Given this list of marker genes YRDC, IL12A, IFT140, RNASEH2A, DNASE1L3, PROKR2, TRAF7, MT-TC (mitochondrially encoded tRNA-Cys (UGU/C), NCBI Gene Id 4511), RPS20, ARX, PRF1, GUCY2D, RD3, STAT4, AFG2B (AFG2 AAA ATPase homolog B), RRM2B, LRAT, CPT1A, LUZP1, PRNP, UBE4B, SP110, PAH, ADAR, MSH2, AGR2, PNPLA6, MMP23B, CBS, PRKCZ, HLA-DPA1, EPCAM, MEFV (MEFV innate immunity regulator, pyrin), PRTN3, GDF6, C4A (complement C4A (Chido/Rodgers blood group)), ATP1A3, SLC1A3, DCC, TTR, TPRKB, POMT1, CRX, CTLA4, MT-CO1, SPATA7, WDR73, USP45, TBC1D24, CRB1, PCYT1A, PMS2, HESX1, MT-TS2, TGFBR3, CFHR3, CYP26C1, MT-CO3, ADSL, LSM11, MT-TL1, TUBB2B, TUBB4B, CRELD1, PRRT2, COQ2, AKT3, PRDM16, PEX7, ARNT2, SNORD118, MT-TQ, OSGEP, MT-ATP8, BAP1, BMPR1A, SMARCAL1, FKTN, SCN1A, TGFBR2, LCA5, ARHGAP31, ATP1A2, PMS1, WDR4, CACNA1A, SAMHD1, CASZ1, RPE65, TP53, SAT1, TTPA, IQCB1 (NCBI Gene Id 9657), HLA-DQB1, GMPPB, POLD1, RBPJ, COL4A2, IRAK1, PHYH, OPA1, RPGRIP1, DNM1L, RNASEH2C, TP53RK, TPP2, KCNAB2, IKBKG, GABRD, NPPA, HRAS, SEMA4A, MT-TV, AKT1, MT-ND5 (NCBI Gene Id 4540), WDR62 (NCBI Gene Id 4181), L1CAM, NMNAT1, RNASEH2B, ARG1, ANO1, MMUT, RNF216, ATM, IMPDH1, HLA-DPB1 (major histocompatibility complex, class II, DP beta 1), GNAQ, HLA-B, PDGFRB, POLE, FUCA1, ERAP1 (endoplasmic reticulum aminopeptidase 1), CFHR1, SLC2A1 (NCBI Gene Id 6513), PDGFB, CRPPA, TLR4, GALC, MTOR, NOTCH3, NAGA, AIPL1, FKRP, CEP290, TSC2, POMGNT1, PLA2G6, TULP1, SMO, OTX2, MEOX1, FGFR1, CHEK2, ABCD1, EOGT, NF2, GBE1, BMP4, ADA2, TBX1, LAGE3, KCNJ13, SMARCE1, FAS, SUFU, SKI, TREX1, MT-CO2, GNB1, BRCA2, ANGPTL6, HTRA1, MT-TK, PDPN, IL23R, HPRT1, NUP107, PTPN22, SPOP, DLL4, SMARCB1, SUOX, TBK1, IFIH1, IL12A-AS1, MT-TH, CFH, LARGE1, AMACR, SPP1, COL3A1, SCN5A, SPEN, TERT, PIK3CA (phosphatidylinositol-4,5-bisphosphate 3-kinase catalytic subunit alpha), MSH6, GUCY1A1, CCR1, HSPG2, MTHFR (NCBI Gene Id 4524), PRORP, NOTCH1, MLH1, KLRC4, TSC1 (TSC complex subunit 1), SLC12A6, ENG, MT-ND6, HMGCL, DOCK8, MT-TW, RNU7-1, POMT2, IFNGR1, GON7, MT-ND4, SOX3, MUTYH, NUP133, MT-TF, SOX2 (SRY-box transcription factor 2), B3GALNT2, DOCK6, PTEN, RERE, MT-CYB, GDF3, RDH12, KRAS, TLR3, THSD1, RHOBTB2, CTC1 (NCBI Gene Id 80169), UBAC2, COL4A1, IL10, MT-ND1, here is a description of the gene set: Human Gene Set: HP_HEMIPLEGIA_HEMIPARESIS species: Homo sapiens Loss of strength in the arm, leg, and sometimes face on one side of the body. Hemiplegia refers to a severe or complete loss of strength, whereas hemiparesis refers to a relatively mild loss of strength. Hemiplegia/hemiparesis